Given this list of marker genes Itpr1, P2rx7, P2rx4, P2rx2, P2rx5, P2rx6, P2rx3, Trpc6, Itpr2, Trpc3, P2rx1, Itpr3, Trpc7, here is a description of the gene set: Elevation of cytosolic Ca2+ levels Mouse Gene Set: REACTOME_ELEVATION_OF_CYTOSOLIC_CA2_LEVELS studied in species Mus musculus